Given this list of marker genes Cep41, Stc1 (NCBI Gene Id 20855), Eps8l2, Map4k5, Ngfr, Ptchd1 (NCBI Gene Id 211612), Nr2f1, Zfp800 (NCBI Gene Id 637385, zinc finger protein 800), Col27a1, Ube2h, Scamp1, Ewsr1, Sgo1, Rabgap1l, Ntrk2, Usp4, Gpatch8, Pbrm1, Mecom (MDS1 and EVI1 complex locus), Vash2, Rasal2, Ica1l, Ppm1j, Gsk3b, Il11 (interleukin 11), Neurod1, Pop4, Kctd10, Mrps30, Slc25a4, Pak5, Krtap12-1, Fam110c, Clec14a, Prrx1, Tmem276, Peli1, Znrf3, Id4, Tanc2, Stag2, 2810459M11Rik (NCBI Gene Id 72792), Cgnl1, Fgf7, Lin9, Perp, Pwwp2a, Flvcr2, 2210408I21Rik, Hs6st2, Cct8, Slc30a7, Mark1, Ascl4 (NCBI Gene Id 67341), Cdkal1, Nfat5, Vrk1, Gapvd1, Sez6l2, Zc2hc1c, Fam20b, Ccser2, Cdip1, Tmem169 (NCBI Gene Id 271711), Chsy1, Dact1, Hectd2, Actc1, Dtl, Uqcc1, Ino80d, Mab21l2, Wdr26, Gm4984, Plscr4, Entpd4, Sptssb, Cyp2c70, Uvssa, Zfp449, Nr2e3, Lrig3, Ext1, Clock, Hmbs, Tes, Folr1, Gm3985, Lhx9, Gask1b, Cers2, Tenm4, Pgap1, Rbm48, Kcnn3, Xylb, Slc2a2, Ints4, Gpr3, Tmem266, Cnep1r1, Fign (fidgetin), Pdyn, Ddo, Ppp6r3, Nsmaf, Crebrf, Cyp2j5, Sh3pxd2a, Serbp1, Usp28 (ubiquitin specific peptidase 28), Hdac9, Vax1, Patj, Hoxd13, Tiparp, Atg13, Tmtc2, Dner, Cd38, Zrsr2, Zkscan8, Zdhhc5, Pafah1b2, Hmgn2, Tnpo3, Rap2a, Hoxc4, Ep300 (NCBI Gene Id 328572), here is a description of the gene set: Mouse Gene Set: MIR_29B_1_5P studied in species Mus musculus Genes predicted to be targets of miRBase v22 microRNA mmu_miR_29b_1_5p in miRDB v6.0 with MirTarget v4 prediction scores > 80 (high confidence targets). from publication Chen Y, Wang X (PMID 31504780)